Given this list of marker genes KPNA1, SRP68, KPNA6, PEX5L, NUP98, NFKBIA, KPNA7, KDELR1, PEX7, KPNA3, NUP214, NUP153, KPNB1, TNPO2, TOMM20, BRAP, SRP54, NPAP1, CEMIP, KPNA4, POM121L2, TNPO1, TOMM22, IPO4, PEX19, KDELR3, SEC61A1, POM121, CABP1, SRP14, KDELR2, POM121C, TOMM20L, KPNA2, PEX5, BABAM2, SEC61A2, KCNIP2, TIMM22, AP2B1 (NCBI Gene Id 163), POM121B, AP2M1, KPNA5, TOMM70, NUP58, RANBP6, IPO5, here is a description of the gene set: Binding to a signal sequence, a specific peptide sequence found on protein precursors or mature proteins that dictates where the mature protein is localized. studied in species Homo sapiens Human Gene Set: GOMF_SIGNAL_SEQUENCE_BINDING